Given this list of marker genes Slc5a1, Hmx1, Themis2, Slc27a2, Otp, Slc6a20a, Htr1a, Cartpt, Doc2a, Celf4, Tafa3, Ky, Nmu, Kcnj6, Alox12, Gal, Dnajc22, Alox12b, Bicdl1, Tacr1, Slc6a5, Gpr4, Fam43b, Foxe3, Cacna2d2 (NCBI Gene Id 56808), Grhl3, Scn8a, Cabp7, Cpxm2, Otop3, Slc12a5 (solute carrier family 12, member 5), Gfi1, Calb1, Rfx4, Bsn, Nalf2, C1ql1, Atp8a2, Sertm1, Rasgef1c, Ntsr1, Aatk, Lrrc26, Dsc2, Kif12, Scn5a, Phactr1, Lrrc9, Fbll1, Crhr1, Fgf17, Hoxb1, Mcf2l, Mtarc1, Tfap2b, Rax, Prdm14, Crh, Oprd1 (NCBI Gene Id 18386), Car4, Unc5a, Tbx21, Lhx5, Irf6, Slc5a8, Kcnq1, C1qtnf4, Tmem181a, Cyp24a1, Trh, Nrxn2, Sst, Astn1, Lingo3, Gjb6, Sel1l3, Stmn3, Lhx3, Dpp10, Cadm3, Cnfn, Otud7a, Chd5, Pax1, Lsr, A330008L17Rik, Dmbx1, Cbln2, Rasef, Grik3 (NCBI Gene Id 329940), Degs2, Emilin3, Celsr1 (NCBI Gene Id 57075), Acp7, Nkx6-2, Acan, Jhy, Oxt, Nkx2-3, Dmrtc2, Pcdh8, Wnt7b (NCBI Gene Id 22422), Hrk, Kl, Tmem59l, Myod1, Mpzl2, Fgf3, Nkx2-9, Scn3b, Lrrc3b, Qrfpr, Cd70, Rap1gap2, Cdx1, Hand1, Dleu7, Foxd3, Dnajc6 (DnaJ heat shock protein family (Hsp40) member C6), Adgrb3, Slc18a2, Apoa5, Ephx3, Rab11fip4, Nrros, Boll, Vwc2, Tacstd2, Matn4 (matrilin 4), Vstm2b, C1ql2, Srcin1, Csmd1, Neurod2, Lhfpl4, Rimkla, Grhl2, Prmt8, Tcf20, Adam11, Prdm8, Scnn1b (NCBI Gene Id 20277), Wscd1, Nkx6-1 (NCBI Gene Id 18096), Cpne7, Onecut3, Shisa6, Ntm, Cyp27b1, Prom2, Slco4c1, Mmp24, Khdc3, Irs3, Alox15, Nr4a3, Ucn, Six6, Chrnb2, Mmp9, Lypd3, Tdh, Cpn1, Tmem179, Acaa1b, Ptprt, Nags, 4930447C04Rik, Paqr6, Jag2, Mal, Grk3, Dsg2, Sox2, Srrm4, Lrtm2, Slc5a5, Kcnb1 (NCBI Gene Id 16500), Epha8, Plpp4, Otop1 (otopetrin 1), Gfra3, Cbln4, Tmem130 (NCBI Gene Id 243339), Kcnc3, Prr36, Kcnj10, Vstm2a, Shtn1, Lgi2, Nrtn, Sowaha, Tcerg1l, Tnfrsf9, Kdf1, Olig1, Ache, Tcf21, Tmem174, Dscam, Galr1, Rspo1, Elovl3, Cntn2, Slc8a2, Kcns2, Slc15a1, Avp, Ttc22, Trpm3, Thbs4, Tfap2c, Fndc5, Ly6h, Fezf2, Grin2a, Aifm3, Rapgef4, Ptf1a, Tmem229a, Myrip, Chga, Kcnt1, Acsl6, Dll3, Zfp804a, Snhg11, Rspo4, Klhl14, Hrh2, Lmx1a, Nr2e1, Ikzf3, Iqsec3, Padi2, Wnt10a, Aard, Slc35f3, Ntrk3, Cpne9, Ap1m2, Chrna3, Pou4f3, Cdx2, Kcnq3, Lrfn5, Irx4 (Iroquois homeobox 4), Pyy, Sncb, Gata5, Wnt4, Sprn, Fbp1, Pacsin1, Ppm1n, Vsx1, Kcna2, Npas1, Jph3, Fcho1, Kcnd3, Cspg5, Sfrp5, Rundc3a, Spock1, Dscaml1, Kcns1, Diras1, Ppp2r2c, Lamp5, Mapk8ip2, Des, Insl3, Dpys, Slc34a2, Bcan, Lypd4, Slc30a2, Cntn4, T, Grid1, Marchf4, Cacna1e, Adra2c, Tulp1, Fgfr4, Foxl1 (NCBI Gene Id 14241), Cblc, Glp1r, Psd2, Lin28a, Slc22a3, Tmem114, Aqp5, Tmprss2, Hcn1, Dmrt3, Phox2b, Marveld3, Cracr2b, Sorcs3, Six3, Hoxb3, Slc7a10, Fgf20, Foxn4, Dkkl1, Brsk2, Zmat4, Tekt4, Tal1, Ttyh1, Scgn, Cdh8, Camk2b, Ncmap, Gria2, Ppp1r16b, Fgf12, Insm1, Atp2b2, Tacr3, Hes2, Reln, Slc17a6, Npy5r, Calcr, Bmp8b, She, Phox2a, Ajm1, Insm2, Prrt3, Cwh43, Nkx2-1, Krt83 (NCBI Gene Id 100126226), Rasal1, Spag6, Pik3cd, Pou4f1, Cdcp1, Eef1a2, Dbx1, Amn, Cpz, Tlx3, Kcnh8, Prrt1, Tubb4a, Amer3, Cimip2c, Srd5a2, Pnmt, Gad1, Foxd4, Necab2, Calb2, Ihh, Barx1, Fgf4, Fev, Syt10, Crtac1, Galnt6, Wnt3a, Cd164l2, Dcc, Sct, Ffar4, Gjd2, Pou3f3, Znrf4, Slc26a5, Sptbn2, Cldn4, Ngb, Bhmt2 (betaine-homocysteine methyltransferase 2), Lamc3, Syndig1l, Rbfox3, Doc2b, Aqp3, Plbd1, Atp1a3, Uncx, Dclk3, Svop, Grm1, Rasgrp2, Crhbp, Hoxd4, Kcnh5, Elavl2, Alx1, Ccdc92b, Pou2f3, Htr4, Ikzf1, Oxtr, Dhh, Mos, Sez6l, Phf24, Chat (choline O-acetyltransferase), Fgf11, Mgat5b, Pou4f2 (POU domain, class 4, transcription factor 2), Nkx1-2, Tlx1, Slc13a3, Nphs2 (nephrosis 2, podocin), Golga7b, Slc32a1, Slc45a1, Lad1, Sstr5, Foxg1, Slc6a11, Sgsm1, Kcnh1, Cplx2, Drd2, Scube1, Cckbr, Car10, Sypl2, Tbx20, Slc9a3, Igfbpl1 (NCBI Gene Id 75426), Pfn3, Pcnx2, Exoc3l2, Tfap2e, Fam163a, Tnxb, Dok7, Cplx1, Hrh1, Kcnip1, Fstl4, Large2, Pdx1, Ptgdr, Neurog1, Neto1, Rbmxl2, Tmem215, Abcc8, Foxb1, Alk, Slc47a1, Fam163b (family with sequence similarity 163, member B), Hmx2, Adgrb1, Gprin1, Plekhg6, Kcnc1, Mast1 (NCBI Gene Id 80677), Lrat, Fgf14, Nxph1, Tnni3, Kndc1, Pax7, Slc16a11, Grin3b, Mmd2, Nkx2-5, Hoxc13, Gpr12, Adcyap1, Gsx1, Tmem171, Gng13, Tcf15, Vsx2, Foxa2, Gabrg3, St8sia3, Sox1, Htra3, Ugt8a, Slc6a7, Hes3, Sall4, Dlgap2, Kcnq2, Lhfpl5, Asic4, Rhcg, Il10ra, Rbpjl, Paqr5, Plin5, Epha6, Snap25, B3galt5, Actn2, Slc46a2, Psd, Neurog3, Scrt1 (scratch family zinc finger 1), Grp, Tcte1, Kcna5 (NCBI Gene Id 213586), Apba2, Bhlhe23, Nhlh2, Grin2c, Gsx2, Crym, Mpped1, Cdh20, Slit1, Onecut2, Plk5, Ptprn2, Hs3st2, Skap1, Adra1a, Ecel1, Cimap1b, Barhl1, Kcnv1, Ghsr, Slc6a1, Neurod1, Nell1, Stk32b, Selenov, Chgb, Tfap2d, Rab37, Cyp4f39, Disp3, Ferd3l, Nkx2-2, Lamc2, Vax1, Lbx2, Kcna7, Mfsd6l, Slitrk3, Prss50, Phactr3, Prkcz, Elfn2, Hba-x, Gpr26, Wnt9b, Luzp2, Skor1, Hes5, Syt7, Olig2, Crb3, Olig3, Kcnh7, Olfml2a, Wnt7a, Ttc9b, Barhl2, Pax8, Slc6a2, Emx1, Gstt2, Alox5, Prlr (prolactin receptor), Cldn6, Sctr, Tmem91, Myo5c, Atp12a, Nrg3, Igsf21 (NCBI Gene Id 230868), Dmgdh, Actl6b, Dmrt1, Cdk5r2, Ryr2, Cnnm1, Tmem150c, Atp8b3, Gabra5, Lbx1, Shh, Gp1bb, Pou3f2, Chrna4, Slc7a14, Lefty2, Sox18, here is a description of the gene set: Genes with high-CpG-density promoters (HCP) bearing histone H3 trimethylation mark at K27 (H3K27me3) in MEF cells (embryonic fibroblast). We report the application of single-molecule-based sequencing technology for high-throughput profiling of histone modifications in mammalian cells. By obtaining over four billion bases of sequence from chromatin immunoprecipitated DNA, we generated genome-wide chromatin-state maps of mouse embryonic stem cells, neural progenitor cells and embryonic fibroblasts. We find that lysine 4 and lysine 27 trimethylation effectively discriminates genes that are expressed, poised for expression, or stably repressed, and therefore reflect cell state and lineage potential. Lysine 36 trimethylation marks primary coding and non-coding transcripts, facilitating gene annotation. Trimethylation of lysine 9 and lysine 20 is detected at satellite, telomeric and active long-terminal repeats, and can spread into proximal unique sequences. Lysine 4 and lysine 9 trimethylation marks imprinting control regions. Finally, we show that chromatin state can be read in an allele-specific manner by using single nucleotide polymorphisms. This study provides a framework for the application of comprehensive chromatin profiling towards characterization of diverse mammalian cell populations. from publication Mikkelsen TS, Ku M, Jaffe DB, Issac B, Lieberman E, Giannoukos G, Alvarez P, Brockman W, Kim TK, Koche RP, Lee W, Mendenhall E, O'Donovan A, Presser A, Russ C, Xie X, Meissner A, Wernig M, Jaenisch R, Nusbaum C, Lander ES, Bernstein BE (PMID 17603471) species: Mus musculus Mouse Gene Set: MIKKELSEN_MEF_HCP_WITH_H3K27ME3